The following is a description of a gene set: Human Gene Set: HP_RENAL_FIBROSIS Renal fibrosis Renal fibrosis is the consequence of an excessive accumulation of extracellular matrix that occurs in virtually every type of chronic kidney disease. species: Homo sapiens, and this is the list of marker genes: SLC37A4, NDUFAF6, CLCN5, PTPRO, ACP5, SLC7A7, NPHP4, BSND, NPHP1 (NCBI Gene Id 4867), GBE1, ARL3, REN, MUC1, NPHP3, PKHD1, ANTXR1